The following is a description of a gene set: from publication Chen Y, Wang X (PMID 31504780) studied in species Homo sapiens Genes predicted to be targets of miRBase v22 microRNA hsa-miR-6751-5p in miRDB v6.0 with MirTarget v4 prediction scores > 80 (high confidence targets). Human Gene Set: MIR6751_5P, and this is the list of marker genes: LDHA, SETBP1, RAB3A, NOVA2, KIF4B, CRTC1, DSCAML1, NALF2, PRR3, MAGI3, NUDT5, GNA14, CBX6, ZFAND1, SEPTIN3, CFLAR, SPRR1B, CPN2 (NCBI Gene Id 285280), CTBS, ZSWIM4, SSC5D, FOXP4, DNAJB5, IGDCC3, PRKCA, ASB4, PARP15, PML, NID1, PPP6R2, ACTB, ADAR, LARP4, SFTA3, IGF2, PRR27, AMPH, HACD4, MEIS2, TBC1D30, MRPL3, CITED2, CLIP3, ZDHHC15, PRKCG, C17orf107, KRTAP17-1, SLC45A3, LHX6, ALKBH1, DLX3, LIMK1, HSD11B2, ELK4, HIP1, ZBTB7A, SCRT2, ZNF701, MFN2, ZNF32, ZNF474, ANKRD60, NFIC, COL1A1 (collagen type I alpha 1 chain), DAGLA, DBT, GSTM4, C1QB, CCDC186